The following is a description of a gene set: Human Gene Set: GOBP_FUNGIFORM_PAPILLA_MORPHOGENESIS The process in which the anatomical structures of the fungiform papilla are generated and organized. The fungiform papilla is a mushroom-shaped papilla of the tongue. species: Homo sapiens, and this is the list of marker genes: HDAC2, SIX4, SIX1, HDAC1, CTNNB1